The following is a description of a gene set: part of: Kidney development Visible kidney development initiates with the formation of the pronephros and then the mesonephros. In amniotes these are transitory structures that are superseded by formation of the metanephros, the functional kidney that persists into adulthood. The nephric duct appears during development of the pronephros and then extends caudally in the mesonephros, inducing the formation of mesonephric tubules that drain into the nephric duct and provide blood filtration in the embryo. (The mesonephric duct is also called the Wolffian duct.)<br>Subsequently, the metanephros is initiated by formation of the ureteric bud in the nephric duct due to the interaction between the nephric duct and the adjacent metanephric mesenchyme. The ureteric bud will grow to become the ureter, branch further, and induce the formation of nephrons and collecting ducts at the termini of the branches. Development of the ureteric bulge is regulated by reciprocal signals passed between the nephric duct and the metanephric mesenchyme. Nephronectin (NPNT) secreted by the nephric duct interacts with Integrin alpha8/beta1 (ITGA8) on the metanephric mesenchyme to activate expression of GDNF in the metanephric mesenchyme. GDNF secreted by the metanephric mesenchyme then binds and activates the RET tyrosine kinase located in the plasma membrane of nephric duct cells. RET activates expression of WNT11 in the nephric duct to regulate differentiation. The extent of kidney development is circumscribed by inhibitory signals provided by ROBO2:SLIT at the duct-mesenchyme interface and by FOXC1,2 from the paraxial mesoderm. species: Homo sapiens Reactome Pathway: Formation of the ureteric bud, and this is the list of marker genes: HOXC11 (NCBI Gene Id 3227), ITGB1, NPNT, WNT11, SIX1, EYA1, HOXA11, ITGA8, GREM1, FOXC1, RET, SLIT2, SIX2, GDNF, HOXD11, FOXC2, ROBO2, PAX2, SALL1, BMP4, GFRA1